The following is a description of a gene set: Human Gene Set: GSE4590_LARGE_PRE_BCELL_VS_VPREB_POS_LARGE_PRE_BCELL_UP species: Homo sapiens Cells from four develppmental stages were purified by FACS from human bone marrow samples Genes up-regulated during B lymphocyte differentiation: large pre-B II versus VPREB1+ pre-B Il. from publication Hoffmann R, Lottaz C, Kühne T, Rolink A, Melchers F (PMID 17890238), and this is the list of marker genes: CRLF3, TMEM50B (NCBI Gene Id 757), B3GNT2, SAMD9L, CD200 (NCBI Gene Id 4345), LIMS1, PI4K2B, ARMCX4, ZEB2, ANXA2, MTA3, S100A10, PLA2G4A, LAIR1, CLEC2D, OXR1, SNX10, CTLA4, CDC42EP3, TACC1, CDKN1A, OSBPL1A, GPR174, ITGA4, DOCK11, AIM2, ATXN7L1, ANKS1A, DDX60, TDRKH, HDAC4, PAN3, HMGCS2, NEDD4L, ARHGAP18, NCOA7, RRP1B, SLC15A4, MSMO1, TOX3, NPC1, GRAP2, MYL10 (NCBI Gene Id 93408), ELF2 (E74 like ETS transcription factor 2), ERG, SKAP2, PRKAG2, PLCB4, GOLPH3L, NCKAP5, MGAT4A, NEBL, ARL5C, HMGCR, TGFBR1, RNF216, SMAP2, TBC1D31, PRRG4, PPP1R12A, MCOLN2, XBP1, SLC27A2, SRP68, E2F2, DHCR24, ALPK1, OGFRL1, MYOF, FUT8, SNX9 (NCBI Gene Id 51429), HYCC1, MUC13, PARP8, NKG7, HSD11B1, ATP8B4, PDE5A, ARMCX3, ADGRG1, RCN1, ZBTB20, PCTP, PLAAT3, IFT80, EPCAM, RAB3GAP2, ACOT7, DNAI4 (dynein axonemal intermediate chain 4), CDK20 (cyclin dependent kinase 20), PLXDC1 (NCBI Gene Id 57125), IDI1, LARGE1, TMEM71, TBC1D9B, CALCRL, ATRNL1, CAMKV, S100A11, STXBP5, USP19, GNAQ, TSPAN2, DGKE, PRKCA, TPD52, NT5C2, SLC66A3, SNX30, PLAG1, EMC3, CDK6, TCF7L2, ATG4C, CHD9, TGFBR3, PIK3CD, FNBP1L, PPT1, ZDHHC14, SUSD1, IFNGR1, RNASEL, RNF130, CUX1, PAPSS2, UCK2, CMAHP, LY6D, GM2A, RIGI, RNF13, WFDC11, TRAM2, EFHC1, H19, ITGB4, SLC12A2, PTPDC1, DSTN, TIFA, MIR340, SESTD1, RPTOR, CYP51A1, CPNE2, LDLR, ANKS3, EZH1, KIT (NCBI Gene Id 5086), RAB38, ADD3, GBP6, FRMD4A, PLEKHA7, SLC25A12, UVRAG, HSPA4L, DOCK8, RAB3IP, PLD4, CD79B, KCNK5, CYB561A3, ETNK1, CBLB, DNAJC6, RGS18, GBP4, LTA4H (leukotriene A4 hydrolase), HP1BP3, SLC25A45, ARPP21, PCGF5